The following is a description of a gene set: Mouse Gene Set: GOMF_3_HYDROXYACYL_COA_DEHYDRATASE_ACTIVITY Catalysis of the reaction: a 3-hydroxy-fatty acyl-CoA = a (2E)-enoyl-CoA + H2O. species: Mus musculus, and this is the list of marker genes: Echs1, Hsd17b4, Hacd3, Hacd2, Hadha, Cdyl, Hacd1, Hacd4, Ehhadh